The following is a description of a gene set: Irregular capital femoral epiphysis Human Gene Set: HP_IRREGULAR_CAPITAL_FEMORAL_EPIPHYSIS studied in species Homo sapiens Irregular surface of the normally relatively smooth capital femoral epiphysis., and this is the list of marker genes: RNU4ATAC, ADAMTSL2, PEX5, TRPV4, UFSP2, COL9A1